The following is a description of a gene set: Abnormal lung development studied in species Homo sapiens Human Gene Set: HP_ABNORMAL_LUNG_DEVELOPMENT A structural defect associated with abnormal development of the lung., and this is the list of marker genes: SLC18A3, WNT3, RSPH1, DGCR8, BUB1, BMPER, TAPT1, IFT81, TCTN3, SPECC1L, DNAJB13, SLC26A2 (NCBI Gene Id 1836), COQ7, SLC25A24, COMT, KIF21A, RBM10, LETM1 (NCBI Gene Id 3954), PIGN, DNAAF1, NEK9, DNAI1, TTC21B, IFT140, GRIP1, GAS2L2, CHRM3, KIAA0586, MAGEL2, FGFR3, DNAAF4, CHUK, ALDH1A2, ETFB, HIRA, DLK1, JMJD1C, CFAP300, MCTP2, NELFA, DNAAF6, WNT7B, LONP1, DOK7, GLDN, FREM2, TBX1 (NCBI Gene Id 7413), DNAH11, AGTR1, STRA6, PRKACA, RLIM, PRDM10, LBR, RPGR, PRKACB, BCOR (NCBI Gene Id 57686), UFD1 (ubiquitin recognition factor in ER associated degradation 1), CFAP74, MYH3, NEK10, GDF1, WDR19, ODAD4, RTL1, FLNA, TMEM94, FOXJ1, EVC (NCBI Gene Id 7886), MKKS, CC2D2A, KLHL41, ETFDH, NSDHL, WNT4, KLHL40, CUX1, PIGT, TRIP4, MEIS2, ALG9, RET, NEK1, EVC2, ACE, PIEZO2, KAT6B (lysine acetyltransferase 6B), TUBA1A, GREB1L, DHCR7, BUB1B, NME5, FGF20, GLI1, NSD2, LTBP4, DONSON, RARB, STK36, ESAM, FUZ, ARVCF, AKT1, CDC45, GATA6, NUP88, LGI4, DYNC2LI1, DGCR2, MKS1, BUB3, SLC31A1, ZFPM2, HSPG2, PKHD1, DYNC2I2, PHGDH, MYOD1, ASCC1, SEC24C, NKX2-6, WNT9B, NPHP3, DGCR6, ALG3, PUF60, DNAH1 (NCBI Gene Id 25981), CEP55, DNAAF5, LMOD3 (NCBI Gene Id 56203), GLI3, SPEF2, SF3B2, KIAA0753 (KIAA0753), CPLX1, OFD1, DPAGT1, PORCN, INTU, SMO, FLCN, CHRNG, FOXF1, DZIP1L, TRPV4, GPKOW, REN, RYR1, PLXND1, NODAL, PI4KA, HYLS1, FAM20C, DNAI2, RSPH4A, GPC3, TTC12 (NCBI Gene Id 54970), ACTA1, ZMYND10, LMNA, CSPP1, COL2A1, ETFA, INVS, DNAAF2, ODAD2, IFT172, DNAH5, DYNC2H1, ODAD1, CFAP221, LIFR, ZMPSTE24, NME8, HOXD13, GBA1, DRC1 (dynein regulatory complex subunit 1), ZIC3 (Zic family member 3, NCBI Gene Id 7547), SETBP1, PIGG (NCBI Gene Id 54872, phosphatidylinositol glycan anchor biosynthesis class G (EMM blood group)), CFAP298, PEX1, CEP120, MCIDAS, SCN4A, RREB1, DNAAF11, TRIP11, MEG3, FRAS1, AARS2, DNAAF3, ESS2, PTH1R, EMG1, TRIP13, GPC4, ATP5F1A, DYNC2I1, CTBP1, ITGA8, VANGL1 (NCBI Gene Id 81839), RAB34, WDR35, CCDC39, FLNB, GP1BB, CHRND, CCDC40, WT1, RAPSN, NEK8, RSPO2, GLE1, B3GALT6, TXNDC15, ADGRG6, PRRX1, NEB, CTNNA2, TBX4 (T-box transcription factor 4), MUSK, SPAG1, FANCB, AGT, MYRF, LRRC56, NAA10, NDUFB10, CHRNA1, RSPH3, RSPH9 (radial spoke head component 9), DNAL1, HYDIN, CCNO, MYH11, SON, ODAD3, DNAH9, GFRA1, CEP57, IFT80